Given this list of marker genes TLCD1, CNN1, MYL9, ISLR, TRIM39, RELN, APOD, PRELP, FRYL, SERPINF1, ACTA2, TNS1, GABBR1, TNNI2, MEF2C, MYLK, IGFBP5, here is a description of the gene set: Human Gene Set: HOLLERN_ADENOMYOEPITHELIAL_BREAST_TUMOR Genes that have high expression in mammary tumors of adenomyoepithelial histology. Human breast cancer has been characterized by extensive transcriptional heterogeneity, with dominant patterns reflected in the intrinsic subtypes. Mouse models of breast cancer also have heterogeneous transcriptomes and we noted that specific histological subtypes were associated with particular subsets. We hypothesized that unique sets of genes define each tumor histological type across mouse models of breast cancer. Using mouse models that contained both gene expression data and expert pathologist classification of tumor histology on a sample by sample basis, we predicted and validated gene expression signatures for Papillary, EMT, Microacinar and other histological subtypes. These signatures predict known histological events across murine breast cancer models and identify counterparts of mouse mammary tumor types in subtypes of human breast cancer. Importantly, the EMT, Adenomyoepithelial, and Solid signatures were predictive of clinical events in human breast cancer. In addition, a pan-cancer comparison revealed that the histological signatures were active in a variety of human cancers such as lung, oral, and esophageal squamous tumors. Finally, the differentiation status and transcriptional activity implicit within these signatures was identified. These data reveal that within tumor histology groups are unique gene expression profiles of differentiation and pathway activity that stretch well beyond the transgenic initiating events and that have clear applicability to human cancers. As a result, our work provides a predictive resource and insights into possible mechanisms that govern tumor heterogeneity. species: Homo sapiens from publication Hollern DP, Swiatnicki MR, Andrechek ER (PMID 29346386)